The following is a description of a gene set: studied in species Homo sapiens Any process that stops, prevents or reduces the frequency, rate or extent of glycoprotein metabolic process. Human Gene Set: GOBP_NEGATIVE_REGULATION_OF_GLYCOPROTEIN_METABOLIC_PROCESS, and this is the list of marker genes: SLC2A10, MGAT4D, ITM2A, BACE2, ITM2C, MIR144, MIR31, MIR520C, ITM2B, CST3, MIR455, MIR298, MIR153-1 (microRNA 153-1), APCS, MIR106A, MIR147A, MIR20A, MIR323A, PTX3, MIR644A, AGO2, AATF, JAK3, ACOT8, MIR101-1, ABCA7, MIR17